Given this list of marker genes Ube2s, Anapc7, Cdk4, Psmb5, Orc3, Psmc2, Mcm8, Ccna1, Gins3, Pola1, Rfc1, Psmd7, Psmb7, Psmc6, Psma2 (proteasome subunit alpha 2), Psma3, Anapc2, Smc3, Psmc1 (NCBI Gene Id 19179), Cul1, Psma6, Psmc5, Cables1, Pold2, Pcna, Wee1, Ube2c (NCBI Gene Id 68612), Psmb4, Orc1, Orc5, Pole2, Gmnn, Ccne2, Orc4, Ccnd1, Prim1, Gins1, Cdkn1b, Psmc3, Cdkn1a, Psmd1, Psma5, Ube2d1, Ubb, Ccne1, Cdc6, Psma4, Psmd13, Psma7, Esco1, Anapc15, Psma1, Cdc23, Rb1, Ube2e1, Psmb6, Rpa1, Pola2, Rfc3, Fzr1, Rps27a, Cdc26, Esco2, Mcm4, Anapc10, Dna2, Mcm7, Mcm2, Lig1, Pold1, Ccnh, Pole, Psmd6, Psmc4, Pold4 (polymerase (DNA-directed), delta 4), Stag1, Rad21, Psmd12, here is a description of the gene set: electronically inferred by orthology from the curated human pathway Reactome Pathway: S Phase part of: Cell Cycle, Mitotic species: Mus musculus This event has been computationally inferred from an event that has been demonstrated in another species.<p>The inference is based on the homology mapping from PANTHER. Briefly, reactions for which all involved PhysicalEntities (in input, output and catalyst) have a mapped orthologue/paralogue (for complexes at least 75% of components must have a mapping) are inferred to the other species.